Given this list of marker genes Art4, Upp1, Large1, Parp8, Poglut3, Nampt, Upp2, Art3, Art2a, Parp16, Gxylt1, Aprt, Gxylt2, Potefam3b, Qprt, Parp6, Parp10, Art2b, Poglut2, Parp1, Art5, Xylt2, Sirt4, Art1, Lacc1, Parp9, Arf4, Parp12, Parp2, Parp3, Arl6, Qtrt1, Tiparp, Pnp, Ppat, Xylt1, Parp4, Potefam3a, Mtap, Large2, Tymp, Tnks2, Sirt6, Rxylt1, Hprt1, Parp11, Xxylt1, Pnp2, Ankrd66, Parp14, Qtrt2, Zc3hav1, Tnks, Sirt2, Poglut1, Umps, here is a description of the gene set: Catalysis of the transfer of a pentosyl group from one compound (donor) to another (acceptor). Mouse Gene Set: GOMF_PENTOSYLTRANSFERASE_ACTIVITY studied in species Mus musculus